The following is a description of a gene set: species: Homo sapiens The process whose specific outcome is the progression of the vasculature of the retina over time, from its formation to the mature structure. Human Gene Set: GOBP_RETINA_VASCULATURE_DEVELOPMENT_IN_CAMERA_TYPE_EYE, and this is the list of marker genes: COL4A1, ARHGEF15, ROM1, NRP1, VSTM4, FZD4, LRP5, ACVRL1, ACVR2B, NDP, CYP1B1, PDGFRB, BMPR2, RHOJ, CLIC4, HIF1A, TGFB1, LARGE1, PDGFRA, LAMA1